The following is a description of a gene set: species: Homo sapiens Human Gene Set: HP_CHORIORETINAL_ATROPHY Atrophy of the choroid and retinal layers of the fundus. Chorioretinal atrophy, and this is the list of marker genes: RNU7-1, NDP, CYP4V2, ACVRL1, EYS, GUCY2D, SPATA7, CRB1, ROM1, TEAD1, SLC25A15, FSCN2, PAX2, NDE1, HADHA, NRL, C1QTNF5, RPE65, JAG1, CFH, CFI, GUCA1A, PRPH2, COL18A1, LRP5, EFEMP1, SAG (S-antigen visual arrestin), CDH3, PNPLA6, VCAN, CHM, OAT, RPGRIP1, HMX1, LRAT, LCA5, CLCN2, TIMP3, CRX, KRAS, ZNF408, CTNNB1, TSPAN12, FZD4